The following is a description of a gene set: Many vaccines induce protective immunity via antibodies. Systems biology approaches have been used to determine signatures that can be used to predict vaccine-induced immunity in humans, but whether there is a 'universal signature' that can be used to predict antibody responses to any vaccine is unknown. Here we did systems analyses of immune responses to the polysaccharide and conjugate vaccines against meningococcus in healthy adults, in the broader context of published studies of vaccines against yellow fever virus and influenza virus. To achieve this, we did a large-scale network integration of publicly available human blood transcriptomes and systems-scale databases in specific biological contexts and deduced a set of transcription modules in blood. Those modules revealed distinct transcriptional signatures of antibody responses to different classes of vaccines, which provided key insights into primary viral, protein recall and anti-polysaccharide responses. Our results elucidate the early transcriptional programs that orchestrate vaccine immunity in humans and demonstrate the power of integrative network modeling. Genes positively correlated with antibody response in peripheral blood mononuclear cell in adults (18-45) after exposure to Menomune A/C/Y/W-135, time point 3D from publication Li S, Rouphael N, Duraisingham S, Romero-Steiner S, Presnell S, Davis C, Schmidt DS, Johnson SE, Milton A, Rajam G, Kasturi S, Carlone GM, Quinn C, Chaussabel D, Palucka AK, Mulligan MJ, Ahmed R, Stephens DS, Nakaya HI, Pulendran B (PMID 24336226) Human Gene Set: LI_PBMC_MENOMUNE_A_C_Y_W_135_AGE_18_45YO_CORRELATED_WITH_ANTIBODY_RESPONSE_3DY_POSITIVE species: Homo sapiens, and this is the list of marker genes: MAP3K8, CD80, CD4, WDFY4, HLA-C, CCL5, HLA-G, PDE4B, SLC27A2, HLA-DPB1, EBI3, FAR2, BCL3, ICAM1 (intercellular adhesion molecule 1), IL23A, PTGS2, CD1C, PCTP, NFKB2, PLXDC2, HLA-DRB1, CXCL2, CD9, CD83 (CD83 molecule), ASPH, HMOX1, HLA-DMA, SLAMF8, HLA-A, HLA-DQB1, ATP1B1 (NCBI Gene Id 481), HLA-DPA1, TNF, CD74, IFNG, HLA-DRA, IL1R2, CCL20, PLAUR, HLA-E, NFKBID, CD1B, IL1B